The following is a description of a gene set: Human Gene Set: GOBP_POSITIVE_REGULATION_OF_D_GLUCOSE_IMPORT studied in species Homo sapiens Any process that activates or increases the frequency, rate or extent of the import of the hexose monosaccharide glucose into a cell or organelle., and this is the list of marker genes: MAPK14, RAP1A, OSBPL8, CREBL2, POU4F2, ITLN1, TERT, ERFE, KLF15, OPN3, PRKCI, RHOQ, ARPP19 (cAMP regulated phosphoprotein 19), MEF2A, IRS1, INS, FGF19, PTH, APPL1, GPC3, ADIPOQ, SORBS1, CAPN10, INSR, PIK3R1, C1QTNF12, AKT1, RNASEL, FGF21, IRS2, AKT2, NFE2L2, CLTCL1, OCLN (occludin), PTPN11, SLC1A2, IGF1, MIR223